The following is a description of a gene set: Mouse Gene Set: GOBP_AUTOSOME_GENOMIC_IMPRINTING studied in species Mus musculus The establishment of epigenetic modifications (imprints) in autosomal (non-sexual) chromosomes during gametogenesis, and propagation of these imprints during the organism's life. Genomic imprinting leads to an asymmetry between the maternal and paternal alleles and differential expression of the corresponding alleles. This can happen through heterochromatin formation or differential chromatin loop formation., and this is the list of marker genes: Dnmt3a, Gsk3a, Gsk3b, Airn, Smchd1, Dnmt3b (NCBI Gene Id 13436), Zfp57, Pik3ca, Dnmt3l, Mycn